Given this list of marker genes FFAR3, PAF1 (NCBI Gene Id 54623), CRH, TNIP3 (TNFAIP3 interacting protein 3), PENK, WNT3, BGLAP, TRIP4, WNT3A, IRF3, GPRIN3, BTG2, CD4, CYP24A1, DAG1, SYK, ESRRB, CTSG, SLC5A5, FZD4, AICDA, GRAMD1B, TRIM68, SMARCD1, XBP1, LACRT, RORA, PDE4B, TRIB1, IL1A, CDK12, PCK2, KIF18A, TLR5, MIR224, PGRMC2, UPF1, TNC, SNW1, ABCA1, AKR1C3, TNFAIP3, TCF21, MED1, MLC1, NLRP3, PDCD4, LDLR, CD86, FAM107A, DGKQ, SPHK2 (NCBI Gene Id 56848), HCK, IL36G, ANKK1, WNT9A, LEP, VPS18, OPRK1, CDC73, MIR223, INSIG2, DDRGK1, PAK1, PARP1, GNAS, SCNN1A, DDX18, NKX3-1, EDNRB, PLCG2, MIR187, NCOR1, AHR, NRIP1, FFAR2, GIT1, NFKBIL1, TRERF1, RXRB, EGLN2, CRHBP, E2F1, RNF14, STAP1, CCR5, CD55, MIR6869, PPARGC1B, DDX5, SIRPA (NCBI Gene Id 96784), LTF, ERRFI1, SRC, PRKAA1, CNOT1, IL1F10, FLT3, RUVBL2, KANK2, MAPK14, CCL27, FOXO3, TNFRSF1B, RNF6, NR2C1, NDUFA13, TRIM5, TBX2 (T-box transcription factor 2), WNT5B, ATP1A2, FAM210B, MAP2K3, SELENOS, MMP3, EPHB2, IRAK1, PYCARD, IL36A, PPP5C, EP300, POU4F1, RORB (NCBI Gene Id 6096), PTGFR, IRAK2, DRD2, IRS1, RELA, BPI, HSF1, FIS1, NR4A3, TGFB1, INSIG1, CCL19 (C-C motif chemokine ligand 19), ID3, MIR342, SOX10, CEBPE, NCOA4 (NCBI Gene Id 8031), TFPI, SNRNP70, SREBF1, JUND, LRP6, ADCY8, PRKD1, GBP3, CNOT9, ZNF703, CLDN1, MIR128-1, GDAP1, IL24, LILRB1, PPARA, HSPA1B, STC1, WNT9B, MGST1 (NCBI Gene Id 4257), HSPA8, CD274, CSF3, INHBA, HES1, JAK2, LY86, IRF8, ZC3H12A, MIR17, PPP1R9B, GHRHR, SMO, SMARCA4, PPM1E, PAX2, MALT1, HCN2, GSK3A, EFNB2, SCGB2A1, FZD7, KDM4C, VPS11, PIM3 (Pim-3 proto-oncogene, serine/threonine kinase), PTK2B (NCBI Gene Id 5748), PLSCR3, RHOXF1, CTR9, CCNA2, MIR140, TLR4, RPS6KB1, ANKRD13C, KDM1A, AIFM1 (apoptosis inducing factor mitochondria associated 1), KDM5D, HNRNPD, CXCL10, NOS3, FGF23, PIM1, CREB1, MIF, ESRRA, TP63, PRKCE, HAND2, ADCY6, PTPN22, LDOC1, CD80, BRINP3, P2RY6, LTK, TESC, SSTR1 (somatostatin receptor 1), TMF1, CFLAR, GPBAR1, WNT7B, KLF4, SKP2, BMI1, MIR146A, CASP1, RBFOX2, CREBRF, PPBP, NR3C1, LMO3, PTPN6, PTGDR, OSBPL7, VPS54, ASS1, IL18, IGF1 (insulin like growth factor 1), EPHA3, CHMP5, ZMIZ1, SERPINE1, ZDHHC7, EFNA5, AXL, TICAM1, WBP2, CBX3, ZNF764, HMGA2, UFM1, CCR7, CAPN2, KLF9, WNT11, IL6, TRIM41, CX3CL1, LCOR, WNT10B, H2AZ1, DEFB104A, TBX1, GSTP1, REST, CES1, MEF2C, UBA5, ADTRP, TFAP4, ARID5A, PLPP1 (phospholipid phosphatase 1), ABL1, PABPN1, GPER1, TNIP2, ATP1A3 (ATPase Na+/K+ transporting subunit alpha 3), KCNK4, KCNK10, NR3C2, CCL21, CYP7B1, SRD5A1 (NCBI Gene Id 6715), CRY1, AXIN2, RWDD1, CARD8, PMEPA1, UBE2L3, GPLD1, MAP2K7, ISL1, SLC39A9, LCN2, BCL10, USP26, NUGGC, TAF7, TRIM24, CCL28, RIPK2, PID1, RHOA, PHC1, KCNK2, PRDX2, LATS1, FOS, GSK3B, SSTR4, MYOD1, DEFA5, NTRK3, LITAF, TAF1, NR1H3, SPI1, TIFAB, PRPF8, COL1A1, NOD2, DEFA1B, PHB1, TREM2, YAP1, CD180, GBP5, MYD88, NFKBIZ, IL37, GNG2, CAV3, SCARB1, PRKCA, STRA8 (stimulated by retinoic acid 8), CD200, FZD10, NPAS4, MEIOSIN, CALCOCO1, CASP7, DYNAP, NCOA1, ABL2, SAFB, ABHD2, RAN, DDX17, TWF2, PLCB1, SRARP, SOX9, CD40, DDIT4, LPAR1, RAMP3, CLOCK, SHPK, MAPK3, KMT2D, SHQ1, CPS1, CPT1A, TRAF6, SFRP1, MIR185, PAGR1, ABCB1, TNF, NCOR2, CX3CR1, MIR21, BRCA1, UBE3A, CXCL5, SCNN1G, SSTR2, SMYD3, SBNO2, IRAK3, PTGDR2, CDK19, AKR1C4, TBXA2R, VIM, DAB2, CACTIN, ADAMTS13, CXCL8, LYN, TCF7L2, DEFB104B, RARA, SCIMP, AKR1C2, FGFR2 (NCBI Gene Id 2263), XPO1, RORC, GNAI1, UBR5, RXRA, PTGER4, RXRG, CCNB1, DEFB118, NFKB1, UFSP2, ZNF366, GRAMD1C, PDE3A, HDAC2, ZNF683, BAD, YES1, BMAL1, AKAP8, PDCD1LG2, GPR155, ALDH1A2, EDN1, BRINP2, NEDD4, SNAI2, TNIP1, NLRP7, FOXP1, CNOT2, TLR9, MSN, FECH, CYP7A1, CYP27B1 (cytochrome P450 family 27 subfamily B member 1), VDR, CRY2, SSTR5, ANKRD1, CAMP, HADHB, FES, PGR, ADCY2, MYB, MT-ND3, NR2E3, ATP5F1A, PDK3, CD36, MMP2, FBP1, STRN3, CASR, SPON2, METTL21C, LBH, SAFB2, MIR433, NODAL, MAP4K1, UFL1, MIR92A1, FOXA1, CYP26B1, CCL2, HEYL, PTPN11, CXCL9, HMGCS2, IL1B, SLC7A5, DNAAF4, IL10, WNT2, PARK7, TICAM2, IRAK4, MSTN, HOXA2, FBXO32, ESR2, CMPK2, CXCL13, IL36B, CARD17P, PHB2, FCAR, INHBB, FDX1, LILRB2, LPL, PPARD, NCOA3, PHEX, HMGB1, PADI2, EIF4E, WNT5A, ROCK2, NCF1, YWHAH (NCBI Gene Id 7533), CXCL6 (C-X-C motif chemokine ligand 6), FKBP4, DAXX, NFKBIB, IL12B, HMGB2, MN1, ZBTB7A, FSHR (follicle stimulating hormone receptor), NR0B1, MIR182, MSX2, SLC6A4, LILRA2, ZFP36L2, CASP9, NFKBIA, PAQR8, KLRC4-KLRK1, PDK4, HAVCR2, CD14, GNB1, HNRNPU, WNT8B, DAB2IP (NCBI Gene Id 84635), SIRT1, BCR, CEBPB, CST11, USP8, PRKCD, GRAMD1A, LY96, GFI1, MTDH, URI1, DGAT2, CALR, ACACA, GBP2, BRINP1, ACOD1, UCP1, HDAC1, MIR20A, DEFB114, PF4V1, RET, AKR1C1, NOS2, KMO, DEFA3, MMP8, BCL2L11, IL36RN, SASH1, GHSR, MIR96, TNFSF4, KAT5, PLSCR4, B2M, NR1H4, KLRK1, ADCY1, MIR125B1, NPC1, ANXA1, ATP1A1, PKN1, ZNF35, ETNPPL, TLR2, DEFA4, AQP1, PRMT2, DDX54, ZFP36, NFE2L1, ADCY3, DEFA6, MMP9, MAPK1, LRP8, PF4, LBP, CARD16, NR2E1, AR, OSR1, CD68, DEFA1, HSPA1A, RARG, HDAC6, CD6, MYOG, EGFR (NCBI Gene Id 1956), POU4F2, SCGB2A2, PTGER2, PLAA, OR51E2, HDAC5, BMP6, MGARP, WNT6, SERPINF1, TSPO, P2RY4, CFTR, SPP1, PER1, ADCY5, PTCH1, CSF2, PTK7, NR1D1, SCNN1D, KDM3A, ADAM9, ADAM15, ESRRG, FOXH1, ESR1, AKT1, SGK1, PIAS2, MRC1, LANCL2, ATM, IRGM, SCNN1B, PCK1, TADA3, ELK1, CCDC62, HTRA2, CARM1, CDK4, PRKAA2 (NCBI Gene Id 5563), ABCB4, MIR766, MAPK8, ITGA2, TEAD2, ZFP36L1, PTAFR, SIGIRR, GATA1, PAQR7, PTK6, here is a description of the gene set: Any process that results in a change in state or activity of a cell (in terms of movement, secretion, enzyme production, gene expression, etc.) as a result of a lipid stimulus. Human Gene Set: GOBP_CELLULAR_RESPONSE_TO_LIPID species: Homo sapiens